The following is a description of a gene set: studied in species Mus musculus Mouse Gene Set: CUI_TREG_SCF_RESPONSE_UP from publication Cui A, Huang T, Li S, Ma A, Pérez JL, Sander C, Keskin DB, Wu CJ, Fraenkel E, Hacohen N (PMID 38057668) Genes positively differentially expressed in cell type: Treg upon treatment with cytokine: SCF in mouse lymph nodes in vivo. Cytokines mediate cell-cell communication in the immune system and represent important therapeutic targets. A myriad of studies have highlighted their central role in immune function, yet we lack a global view of the cellular responses of each immune cell type to each cytokine. To address this gap, the authors created the Immune Dictionary, a compendium of single-cell transcriptomic profiles of more than 17 immune cell types in response to each of 86 cytokines (>1,400 cytokine-cell type combinations) in mouse lymph nodes in vivo. A cytokine-centric view of the dictionary revealed that most cytokines induce highly cell-type-specific responses. For example, the inflammatory cytokine interleukin-1β induces distinct gene programmes in almost every cell type. A cell-type-centric view of the dictionary identified more than 66 cytokine-driven cellular polarization states across immune cell types, including previously uncharacterized states such as an interleukin-18-induced polyfunctional natural killer cell state., and this is the list of marker genes: Psmd10, Dcaf8, Htatip2, Tnfaip8l2, Letm2, Pdlim1, Rbm7, Pgm2, Ndufs4, Dgka (NCBI Gene Id 13139)